The following is a description of a gene set: from publication Motenko H, Neuhauser SB, O'Keefe M, Richardson JE (PMID 26092688) Mouse genes annotated to preneoplasia (MP:0002009) retrieved from the Mouse Genome Informatics database via MouseMine Mouse Gene Set: MP_PRENEOPLASIA studied in species Mus musculus, and this is the list of marker genes: Pdcd4, Ar, Bmpr1a, Vhl, Rb1, Nkx3-1, Klf4, Prkdc, Acd, Ptger4